The following is a description of a gene set: species: Homo sapiens Telomere C-strand (Lagging Strand) Synthesis Human Gene Set: REACTOME_TELOMERE_C_STRAND_LAGGING_STRAND_SYNTHESIS, and this is the list of marker genes: RPA2, POLD4, TERF1, DSCC1, RPA3, RFC2, CHTF8, DNA2, RFC4, BLM, WRN, PRIM1, LIG1, PRIM2, POLA2 (NCBI Gene Id 23649), POLD1, POT1, ACD, RPA1, CTC1, TERF2IP (TERF2 interacting protein), TERF2, RFC1, STN1, PCNA, RFC5, RFC3, FEN1, POLD2, CHTF18, POLD3, TINF2, POLA1, TEN1